Given this list of marker genes RFLNB, PGBD2, MANBA, RALGAPA1, LRRC39, ACBD5 (NCBI Gene Id 91452), B4GALT6, POF1B, PABIR2, GBF1, CXCR4, TBX4 (NCBI Gene Id 9496), PURA, GSK3B, BNIP3, GCN1, WNT3, ROCK2, SLIT2, TMEM178B, CCDC162P, NIPBL, UBE2Q2P13, CCDC88A, OGN, LMO7, TBC1D23, MRPS35 (mitochondrial ribosomal protein S35), LRRC31, ELAVL4, GCSAML, DNAJB4, ATL2, CHD1, CDC37L1, MAFK, NEGR1, ACTR2, GRIA2, CDK1, CYSLTR1, CNTN3, RAB30, INO80D, ARAP1, BCL6, LARP4, LOXL3, DNA2, CDK19, LIN28A, FZD6, RFX7, IFIT2 (NCBI Gene Id 8375), SMAD6, QKI, FOXF1, CDKN2AIP, ANKRD13A, NHLH2, HSD17B11, PTGER4, SLC27A6, PRRC2C, PALS2, IQSEC1, SAMTOR, HTR2C, MDM2, HS2ST1, UGCG, RANBP9, PTPRK, RNF141, TNRC18, USP27X, POGLUT3, ATP10A, MINDY2, ESD, FEM1B, PIK3R2, PDIK1L, GCG, CLEC4C, SPRED1, ZNF451, CDK8, FSD1L, VEGFA, PRG4, PPIL4, MAP3K2 (NCBI Gene Id 51777), NIPSNAP3B, PWWP3B, MACROD2, GRHL1, UGT2A3, ASAH2B, LEMD3, CADM2, HAND2, SELENOF, TPBG, MOSMO, PPA2, LRIG3 (leucine rich repeats and immunoglobulin like domains 3), LPCAT4, USP53, C5orf24, SNX1, FIRRM, SLC1A2, USP42, SLC7A11, CHRNA5 (NCBI Gene Id 1138), AKTIP, ZNF713, CACNB4, CHML, PCCA, PSMC3IP, BTBD1, LDHA, FUBP1, RNF170, PLPP3, AMER2, SHOC2, PRDM11, NFAT5, SP3, C16orf87, MYCBP2, TECTB, IDE, KAT6A, PRDM1, MTMR7, CLIC2, CD2AP, TMEM38B, SETD3, CLMN, CRISPLD1, RPL17-C18orf32, PDE10A, IRX2, ZBTB18, TULP3 (TUB like protein 3), SLMAP, GALNT1, SLC35F1 (NCBI Gene Id 222553), SGMS2, ACKR3, RAD51AP2, ZNF280D, STK4, SLC24A2, C18orf32, IPO7, NEK7, SCUBE1, FAM13C, GRIA4, ZNF326, NTF3, FREM1, SNX13 (NCBI Gene Id 23161), KCNT2, SMAD7, SEMA3A, PGR, MED26, PAPPA (pappalysin 1), SENP7, ESRRG, ITPR2, NPR3, DACT1, RAB27B, RNF139, C1GALT1, SENP3, WDR36, PRDM8, PI4K2B, ZBTB20, CREBBP, SFRP2, ASXL1, WNT5B, CNIH1, DLG2, SUZ12, CLEC4E, CSMD3, SCN3A, ARL14EP, SEC22C, DUSP10, POGZ, MEF2C, ZIC1, PCDH11X, LAPTM4A, AFG1L, CPED1, ANXA4, SPEN, SEMA3F, ZFAND5, XPO4, DLG1, TRIM38, DCP1B, MTX3, RABGAP1 (NCBI Gene Id 23637), GFRA1, CREBZF, C11orf54, CACNA1B, FKBP9 (FKBP prolyl isomerase 9), KCTD9, RAB21, CSPP1, RPGRIP1L, HCK (NCBI Gene Id 3055), PTK2, AHR, CRY1, SGCD, CCAR1, RSPO3, ADAMTS5, PIAS1 (protein inhibitor of activated STAT 1), EAPP, LRRIQ1, SCAF8, GRAMD1B, KHDRBS1, TMED5, CHCHD7, SLC4A7, ARHGEF11, MEX3B, EXTL2, AVPR1A, RORA, ANKRD17, MAP2, PTPRZ1, NBEA, LSM8, ALKBH8, PHYHIPL, HDAC1, MBLAC2, UBA5, RHBDD1, here is a description of the gene set: Human Gene Set: MIR6083 studied in species Homo sapiens Genes predicted to be targets of miRBase v22 microRNA hsa-miR-6083 in miRDB v6.0 with MirTarget v4 prediction scores > 80 (high confidence targets). from publication Chen Y, Wang X (PMID 31504780)